Given this list of marker genes FARP2, PSEN2, CHRNB1, IRF7, CRISP3, SERPINA5, FSHB, SLC6A4, AGT, DGKB, ZNF592, SOX15, ST8SIA5, DCT, NCOA1, TM4SF1, PON3, BMP7, MYBPC2, PPFIBP2 (NCBI Gene Id 8495), MINDY2, H4C2, KPLCE, ITGB6, PPP1CB (NCBI Gene Id 5500), SERPINA6, SBNO2, MINAR1, SLC19A2, ANKS1A, MPHOSPH8, LMNA, IFI6, ARFIP1, SKIL, GPC4, ATXN7, FSTL3, EPHB1, MC1R, SMPD2, AHCTF1, GRAMD1B, TSSK2, ULK2, MYO1A, CA3, WNT5A, SLCO2A1, SLC30A4, BMERB1, ACR, ABCA4, TGFBRAP1, CILK1, RAD54L2, HBZ, GCNT2, ETV3, SLC2A5, GPR12, RAB40AL, KAZALD1, SCML2, FGG, WNT2, LORICRIN, RSC1A1 (regulator of solute carriers 1), RUSC2, CYTH3, C2CD2L, SYCP1, BDNF, GNRH1, DEFB1, ANGPT1, COLQ, F10, UNC93A, CACNA1S, ABCB11, ITGAV, CRACDL (NCBI Gene Id 343990), CCL25, NR4A2, CHRNA2 (cholinergic receptor nicotinic alpha 2 subunit), SPATA2L, NPAS2, KMO, LAMC1, CYP17A1, LIFR, EXTL1, HTR4, RGL1, FST, KLF4, ALDH1A3, GAPDH, H1-4, KIF3B, ITGA9, CYP2F1, STK19, NOL3, INSR, ZC2HC1A, ZNF804A, STBD1 (NCBI Gene Id 8987), NCAM1, MINK1, CBARP (NCBI Gene Id 255057), MYBPC1, SMAD9, SPINT3, KCNN3, ATP4A, MAP3K9, MX1, ARPC1A, GPR37, KCNA1, PBXIP1, STX11, SORT1, BAAT, BLNK, ME1, ATP2B2, CHN1, PEX10, SPRR1A, CENPI, OSM, OLFM1, B4GALT3, RIN1, LTB, SSTR5, RBP4, FAP, EYA1, ATG9A, LMO2, PLCG2, STON1, P2RY2, ADCY8, GLI1, EPO, UCP3, PAX7, CLCN7, NPR2, SELP, NFIA, NOP14-AS1, SERPINE1, TYMP, PRKCE, TSPAN2, ISG15, PPP6R2, SLCO1A2, RAB3B, IQCK, CXCR6, SKIC8, APOD, ICOSLG, LY6E, IKBKE, TSPAN8, WDR13, PLXNA2, EOLA2-DT, OFD1, SLCO1B1, FCGR3B, EN2, PLCD1, DTNB, LEFTY2, ACVR2B, ZNF79, ITGB8, CPM, RNF24, POU3F4, HMHB1, ZNF688, JAG1, DDX28, MAPKBP1, here is a description of the gene set: To understand the functional relationship between brain dendritic cells (brain DCs) and other myeloid cells, we compared the gene expression profile of m/chDCs to that of bone marrow monocytes, brain microglia and classical spleen CD8+ and CD8- DCs. In order to obtain enough brain DCs for mRNA extraction, we expanded brain DCs with in vivo Flt3L treatment before purification. species: Homo sapiens Human Gene Set: GSE29949_CD8_POS_DC_SPLEEN_VS_DC_BRAIN_DN Genes down-regulated in dendritic cells: CD8+ spleen versus brain. from publication Anandasabapathy N, Victora GD, Meredith M, Feder R, Dong B, Kluger C, Yao K, Dustin ML, Nussenzweig MC, Steinman RM, Liu K (PMID 21788405)